Given this list of marker genes Shank3, Clns1a, Ano6, Kcnma1, Clcn3, Prkg2, Kcnn4, P2rx7, here is a description of the gene set: Mouse Gene Set: GOBP_NEGATIVE_REGULATION_OF_CELL_VOLUME Any process that decreases cell volume. species: Mus musculus